The following is a description of a gene set: The clusters of smooth muscle cells (CL14, CL17) also showed features of growth and remodeling: many DEGs of CL17 (such as CRYAB, GJA4) were involved in regulation of immune response and apoptosis, whereas DEGs of CL14 (such as ACTA2, PLN, ADIRF, and MYH11) associated with mature smooth muscle cells (Fig. 3e-g). from publication Fan X, Bialecka M, Moustakas I, Lam E, Torrens-Juaneda V, Borggreven NV, Trouw L, Louwe LA, Pilgram GSK, Mei H, van der Westerlaken L, Chuva de Sousa Lopes SM (PMID 31320652) studied in species Homo sapiens Human Gene Set: FAN_OVARY_CL14_MATURE_SMOOTH_MUSCLE_CELL, and this is the list of marker genes: PKIG, CSRP2, GADD45B, ARPC1B, MAFB, PLN, FIS1, LGALS1, SOD3, ESAM (endothelial cell adhesion molecule), GSN, RHOB, C12orf57, ACTN1, MTHFD2, MYADM, DCTN3, CYB5R3, ID3, CHCHD10, ACTB, IFITM2, TOMM7, ISG15, PTK2, COX8A, PTMA, ID2, ITGB1, PPP1R12A, NDRG2, ARPC5, CALM2, CAVIN3, ATP5PD, COL18A1 (collagen type XVIII alpha 1 chain), NDUFA5, CYSTM1 (NCBI Gene Id 84418), GEM, ASAH1 (N-acylsphingosine amidohydrolase 1), MDH1, PIN1, NUDT4, REEP5 (receptor accessory protein 5), PTP4A3, YWHAH, ACTN4, MT-ND3, NR2F2, CAV1, MAP1B, SDHD, HMGN2, CCDC3, ECH1, SOCS3, CRIP2, EHD2, PHPT1, PLK2, MT1E, IGFBP7, TSPO, RAB2A, IER2, NUCKS1, C4orf3 (NCBI Gene Id 401152), IRF1 (interferon regulatory factor 1, NCBI Gene Id 96501), CD151, INTS6, LBH, NDUFB10, ADIRF, ZFP36L1, ATP5ME, EID1, ESD, MCAM, PDK4, NDUFA4, NTRK2, IER3, CBX6, NOTCH3, TXNIP, LEPROT, WASF2, NET1, PLAC9, NME3, YWHAQ, COX17, ATP5MK, MT-ND4L, PDLIM7 (PDZ and LIM domain 7), SH3BGRL, PEBP1, RAB11B, UGP2, NDUFA3, TPPP3, BRD2, MYL6, HIGD1B, CAV2, WDR1, RERG, AXL (AXL receptor tyrosine kinase), SORBS2, HSPA1B, ARPC1A, SPARC, ARL6IP5, EGR1, PDLIM1, NENF, TBX2-AS1, CALM3, RHOC, ATP5F1D, RHOA, MRPL33, AOC3, HSPA2, JUNB, PFN1, MAP3K7CL, MT-ND1, COX6A1, MFGE8, S100A11, RCAN2, UBB, PGF, RASD1 (ras related dexamethasone induced 1), IFITM3, TAF7, CAPZA2, ALKBH7, RGS5, LHFPL6 (LHFPL tetraspan subfamily member 6), MFAP4, ROMO1, RERGL, BSG, RSU1, FXYD1, PPP1R14A, CD164, FRZB, EBF1, SYPL1, FXYD6, ADAMTS1, HES4, HMGN3, TMEM14C, SELENOM, CRIP1, ACADVL, TUBA1A, ACTA2, HES1, ILK, ADI1, ZFP36, NDUFA13, JUN, APLP2 (amyloid beta precursor like protein 2), DYNLRB1, TGFB1I1, CIRBP, FLNA, LMOD1 (leiomodin 1), CAVIN1, SEPTIN4, PPP1R15A, HSPB1, TSC22D1, ISYNA1, CRYAB, UQCR11, VKORC1, TPM2, ATP5MC1, FKBP8, PTMS, ROCK1, NDUFB1, BCAM, CALM1, BGN, PTN (pleiotrophin), CSRP1, CD44, TINAGL1, BTG2, LGALS3BP, TAGLN (NCBI Gene Id 6876), DSTN, ARID5A, IFITM1, CHMP5, DBI, FOS, RSRP1, MGST3, GNAS, NDUFB7, GPX3, ATP5MC3, RAB13, AP2M1, CCN1, CHURC1, DNAJB1, DYNLL1, COPS6, UQCRQ, PHLDA2, SPARCL1, LGI4, SLIRP, KANK2, SERF2, DYNC1I2, PALLD, BRK1, COX6C, RAC1, ANAPC16, CKB, S100A6, PLS3, ISCU, TBCB, PARK7, OAZ2, KLF10, RASL12, DUT, TPM1, SRSF7, TPM4, CPE, MYL9, CCNI, PPDPF, FOSB, UQCRB, SERPINI1, CTSD, HEXIM1, UBA2, OST4, CAP1, TIMP3, COX6B1, EIF5A, PLP2, MYLK, MGP, EPS8, MT-ND5, NDUFA4L2 (NDUFA4 mitochondrial complex associated like 2), RABAC1, NDN, A2M, TSC22D3, ATF3, MYH11, GUCY1A1, ELOB, VAMP2, DEPP1, MCRIP1, MSRB3, EPAS1, RNH1, NDUFA1, GSTK1, SEPTIN7, RGS16, MEF2C, ATP6AP2, SEPTIN2, SERPING1, GSTP1, SELENOW, UBL5 (ubiquitin like 5), EFHD1, MT2A, HMGB1 (NCBI Gene Id 3146), COX7A2, PSME1, S100A4 (NCBI Gene Id 6275), CALD1, HCFC1R1, IGFBP5, TMEM230, COX5B, SPCS1, COX7A1, CD9, DUSP1, CLIC4